Given this list of marker genes ATP6V1C1, DEPDC1, ROCK2, HPF1, CDK16, SECISBP2L, RPSA, SP1, PURB, ING1, RP9, VAMP3, USP39, TRIM13, DNAJC8 (DnaJ heat shock protein family (Hsp40) member C8), C6orf89, GDE1, HIGD2A, PTTG1IP, RLF, CAPN2, XPO1, UBE2J1, RAN, EMD, TNRC18, RPS11, CRLF2, RORA, RNF146, PLS3, AP3S1, MFGE8, TMED10, SUB1, NOPCHAP1, SRP19, H1-2, CDK12, ATP6V1E1, PJA1, TRAT1, PBDC1, PIK3CG (phosphatidylinositol-4,5-bisphosphate 3-kinase catalytic subunit gamma), PSMD14, AKIRIN2, MTREX, ZNF347, MYOD1, RAB40C, NUDT21, C1orf43, CSNK1D, SMNDC1, CFL1, H2BC5, ID2, ESD, MYB, RAP2B, KLHDC2, NUCKS1, ERI1, SS18L2, ZNF124, TAF1D, VTI1B, LYPLA1, PRR14, TENT5C, BORCS7, ALKBH5, PYCR2, MELK, ATG12, SPCS3, SYCP3, RGS19, KCTD9, PGAM1 (phosphoglycerate mutase 1), AEBP2, RAB11A, MNT, SMC2, ZRSR2, HADH, MKI67, RAMAC, UBE2G2, TMEM106B, LDHA (NCBI Gene Id 3939), RNF19A, ZNF330, EIF2S3, ALAS1, SLC25A51, UBE2K, ZFP36L2, DDIT4, GNAI3, WFIKKN1, CNOT2, LPIN1, C2orf49, CRK, CDKN1B, C15orf39, GRSF1, CNIH1, ABRACL, BATF, HIF1A, VCF1, IL13, NFYB, DUSP10, RAB8B, PLEKHB2, GSK3B, GIGYF1, RBM18, CCPG1, AKR1A1, ARL8B, AMFR, CTLA4, MXD4, GNG10, SOX4, YME1L1, TMEM223, NTM, HDHD3, EIF3C, SLC6A13, ARF6, SLC30A5, CSNK2A2 (casein kinase 2 alpha 2), PTP4A2, VDAC2, SUPT4H1, MTHFD2, CDC42SE1, ZNF24, COPB1, S100A4, DDC, SEPHS2, EIF2B2, CNBP, MTHFS, SELENOK, STMN1, PUS3, ATP5F1D (NCBI Gene Id 513), CNPPD1, IGBP1, PGK1, PCLAF, BNIP3L, MOAP1, LRRC59, EIF3H, TMEM126A, LIPC (NCBI Gene Id 3990), PTGES3, PELO, ADIPOR1, RPN1, CCT2, DAG1, SMAP1, ORMDL1, HELB, EMP1, TMEM115, MRPL9, CFL2, CDKN2D, SLC25A20, ALG2, PTGR3, TMEM60, TPRG1L, SP7, UQCRFS1, FAM107B, SLC25A4, ARPC5, VAPA, VAMP4, GTF2H1, TBL1XR1, PSMD11, PDPK1, SMIM7, RMND5B, HAUS3, MBD2, TRAPPC1, here is a description of the gene set: The adenosine 2A receptor (A2AR) is expressed on regulatory T cells (Tregs), but the functional significance is currently unknown. We compared the gene expression between wild-type (WT) and A2AR knockout (KO) Tregs and between WT Tregs treated with vehicle or a selective A2AR agonist. Genes up-regulated in T reg: untreated versus ZM 241385. from publication Kinsey GR, Huang L, Jaworska K, Khutsishvili K, Becker DA, Ye H, Lobo PI, Okusa MD (PMID 22835488) species: Homo sapiens Human Gene Set: GSE34006_UNTREATED_VS_A2AR_AGONIST_TREATED_TREG_UP